Given this list of marker genes DKK1, IGFL1 (IGF like family member 1), MUCL1, RNASE7, ALOX12B, KLK7, SH3PXD2A-AS1, IL19, DSC1, ESRG, MLIP, TDO2, CYP27B1, ARL14, SPINK6, AMFR, NOS1, SDR9C7, HORMAD1, FLRT3, VEGFC, DSG1, DEFB4A, IL1RL1, MMP28, HLA-DRB4, IL36G, KLK10, CWH43, LINC02577, GPR39, WFDC5, IL12RB2, PCDH7, CDSN, DSC2, KRT75, MMP13, NANOS1, MT1M, ASPRV1, REEP1, KRT1, FLRT2 (NCBI Gene Id 9822), IL36RN, H2BC4, AIM2, SERPINA3, CXCL11, KLK6, NRG1, HSD17B2, PTGS2 (prostaglandin-endoperoxide synthase 2), H4C8, CCNA1, SLITRK6, ABCA12, CT69, CALB2, SPRR2G, NEFL, CPT1A, CALB1, ADGRF4 (adhesion G protein-coupled receptor F4), PAQR5, POPDC3, OLR1, HCG4, KRTDAP, NEFM, HOXA9, SLC6A14, LCE3D, ZBED2, STEAP1B, ENSG00000288081, GAL, EREG, FABP4, DNAH17, PRR9, SLC2A1, SERPINB7, AMDHD1, MGST1, ERAP2, CNTN1, SLC6A15, SLCO1B3, RRAD, CRCT1, SOD2, IL24, TFPI2, SERPINB4, CDA, ENSG00000288062, PTHLH, CNGB1, RGS20, TNC, LINC00460, KLK5, FAM83A, HMGA2, RNF128, S100A12, STEAP4, COL4A6, RDH12, SLC39A2, PSPH, TCHH, KHDC1L, S100A7A, WFDC12, here is a description of the gene set: studied in species Homo sapiens Propensity for subsequent distant metastasis in head and neck squamous-cell carcinoma (HNSCC) was analysed using 186 primary tumours from patients initially treated by surgery that developed (M) or did not develop (NM) metastases as the first recurrent event. Transcriptome (Affymetrix HGU133_Plus2, QRT-PCR) and array-comparative genomic hybridization data were collected. Non-supervised hierarchical clustering based on Affymetrix data distinguished tumours differing in pathological differentiation, and identified associated functional changes. Propensity for metastasis was not associated with these subgroups. Using QRT-PCR data we identified a four-gene model (PSMD10, HSD17B12, FLOT2 and KRT17) that predicts M/NM status with 77% success in a separate 79-sample validation group of HNSCC samples. This prediction is independent of clinical criteria (age, lymph node status, stage, differentiation and localization). The most significantly altered transcripts in M versus NM were significantly associated to metastasis-related functions, including adhesion, mobility and cell survival. Several genomic modifications were significantly associated with M/NM status (most notably gains at 4q11-22 and Xq12-28; losses at 11q14-24 and 17q11 losses) and partly linked to transcription modifications. This work yields a basis for the development of prognostic molecular signatures, markers and therapeutic targets for HNSCC metastasis. Cluster c: genes identifying an intrinsic group in head and neck squamous cell carcinoma (HNSCC). from publication Rickman DS, Millon R, De Reynies A, Thomas E, Wasylyk C, Muller D, Abecassis J, Wasylyk B (PMID 18679425) Human Gene Set: RICKMAN_HEAD_AND_NECK_CANCER_C